The following is a description of a gene set: species: Homo sapiens Human Gene Set: GOMF_ATP_TRANSMEMBRANE_TRANSPORTER_ACTIVITY Enables the transfer of ATP, adenosine triphosphate, from one side of a membrane to the other., and this is the list of marker genes: ANKH, SLC25A42, SLC25A5, SLC25A41, SLC25A23, SLC17A9 (NCBI Gene Id 63910), SLC25A25, SLC35B1, SLC25A31, SLC25A17, PANX1, SLC25A4, SLC25A24, SLC25A6